Given this list of marker genes OAS1 (2'-5'-oligoadenylate synthetase 1), SOCS5, MIR92A1, LGALS9, SELENOK, NR1H4, APOD, GSTP1, IL1B, MCOLN2, SYK, HMGB1, TWIST1, C1QTNF3, OAS3, CLEC7A, TRPV4, ADIPOQ, ERBIN, AGER (NCBI Gene Id 177), here is a description of the gene set: species: Homo sapiens The appearance of monocyte chemotactic protein-1 due to biosynthesis or secretion following a cellular stimulus, resulting in an increase in its intracellular or extracellular levels. Human Gene Set: GOBP_MONOCYTE_CHEMOTACTIC_PROTEIN_1_PRODUCTION